The following is a description of a gene set: studied in species Homo sapiens HSPB3 Human Gene Set: WP_HSPB3, and this is the list of marker genes: ACTA1, MIR1-1, MYOD1, MEF2C, DMPK, HP1BP3, LMNA, H2AZ1, DES, LMNB1, LBR, MYOG, MIR206 (microRNA 206), HSPB3, NOTCH3, HSPB2, CBX5